The following is a description of a gene set: Mouse Gene Set: GOMF_ALPHA_N_ACETYLGALACTOSAMINIDE_ALPHA_2_6_SIALYLTRANSFERASE_ACTIVITY species: Mus musculus Catalysis of the reaction: CMP-N-acetylneuraminate + glycano-(1->3)-(N-acetyl-alpha-D-galactosaminyl)-glycoprotein = CMP + glycano--(N-acetyl-D-galactosaminyl)-glycoprotein., and this is the list of marker genes: St6galnac5, St6galnac2, St6galnac3, St6galnac4, St6galnac1, St6galnac6